Given this list of marker genes Kl, Fgf16, Pik3cb, Pik3c3, Mapk3 (NCBI Gene Id 26417), Fgf5, Flt3l, Pdpk1, Pik3r2, Fgf22, Them4 (thioesterase superfamily member 4), Shc1, Irs2, Fgf10, Klb, Fgfr1, Fgf8, Fgf20, Fgf17, Gab1, Irs1, Fgf7, Fgf15, Grb2 (NCBI Gene Id 14784), Fgf23, Fgf1, Ins2, Tlr9 (NCBI Gene Id 81897), Fgf2, Fgf4, Ins1, Frs2, Fgf6, here is a description of the gene set: part of: Signaling by Insulin receptor This event has been computationally inferred from an event that has been demonstrated in another species.<p>The inference is based on the homology mapping from PANTHER. Briefly, reactions for which all involved PhysicalEntities (in input, output and catalyst) have a mapped orthologue/paralogue (for complexes at least 75% of components must have a mapping) are inferred to the other species. Reactome Pathway: Insulin receptor signalling cascade electronically inferred by orthology from the curated human pathway studied in species Mus musculus